The following is a description of a gene set: electronically inferred by orthology from the curated human pathway studied in species Mus musculus Reactome Pathway: Axon guidance part of: Nervous system development This event has been computationally inferred from an event that has been demonstrated in another species.<p>The inference is based on the homology mapping from PANTHER. Briefly, reactions for which all involved PhysicalEntities (in input, output and catalyst) have a mapped orthologue/paralogue (for complexes at least 75% of components must have a mapping) are inferred to the other species., and this is the list of marker genes: Prkacb, Irs2, Cdc42, Col2a1, Itga2b, Cxcl12, Col9a1, Sptbn4, Dpysl3, Pik3cb, Dpysl2, Itsn1, Sema4d, Artn, Dpysl5, Fyn, Ptk2, Tubal3, Mmp2 (NCBI Gene Id 17390), Trem2 (triggering receptor expressed on myeloid cells 2), Itga5, Gfra2, Grb2, Tyrobp, Ubb, Rps6ka5, Arpc2, Gab1, Nrtn, Dag1, Pak3, Vasp, Tubb4a, Reln (NCBI Gene Id 19699), Frs2, Sema3a, Ap2a1, Epha7, Tuba3b, Nfasc, Yes1, Plxnd1, Mapk7, Arpc4, Tubb6, Tln1, Rnd1, Crmp1, Actr2, Csnk2b, Arpc5, Pfn2, Mapk3, Dok1, Fgfr1, Fes, Map2k2, Pip5k1c, Efnb2, Efna2, Plxna3, Pik3r2, Ranbp9, Epha2, Ptpra, Ap2m1, Lypla2, Col4a2, Ret, Grin1, Prkca, Ptprc, Col6a6, Actr3, Dnm2, St8sia4, Gfra1, Numb, Tuba1a, Dok5, Gdnf, Sptbn2, Rhob, Erbb2, Hras, Shc1, Shc3, Rasa1, Tubb2b, Egfr, Dok4 (NCBI Gene Id 114255), Efna5, Ephb3, Ntn4, Rdx, Arhgef12, Rras, Rps27a, Efna4, Prkaca, Pfn1, Tuba8, Ephb4, Ank1, Gap43, Col6a5, Dok2, Tuba4a, Ap2b1, St8sia2, Evl, Col5a3, Psen1 (presenilin 1), Grin2b, Tuba1b, Tubb4b, Cd72, Ngef, Cxcr4, Shank3, Vldlr, Ephb6, Efnb3, Ap2s1, Cdk5 (NCBI Gene Id 12568), Col6a1, Ncam1, Psenen, Map2k1 (NCBI Gene Id 26395), Tuba1c, Arhgef7 (Rho guanine nucleotide exchange factor), Sdcbp, Efnb1, Ephb2, Ephb1